The following is a description of a gene set: Human Gene Set: GOBP_RNA_GUANINE_N7_METHYLATION The addition of a methyl group to the N7 atom in the base portion of a guanine nucleotide residue in an RNA molecule. species: Homo sapiens, and this is the list of marker genes: WDR4, BUD23, METTL1 (NCBI Gene Id 4234), RAMACL, RNMT, RAMAC, TRMT112